Given this list of marker genes IL1RAP, CHRNA7, PIM1, PIEZO2, ENPP2, PBX3 (PBX homeobox 3), HOXA5, HOXA9, PDGFD, MMP2, SOCS2, GOLGA8A, QPRT, LGALS3BP, ADGRG1, SNRPN, HOXB2, IL2RA, LCT, BAHCC1, CYSLTR2, SMC4 (NCBI Gene Id 10593), MAP1A, COL4A5, TRPC2, NR6A1, HOXB6, SELENOP, HOXB3 (NCBI Gene Id 3213), TRGC1, ADCY2, APP, LYRM1, KCNK5, HOXB5, LAPTM4B, MRC1, TRIM16, HOXA4, MAGED1 (MAGE family member D1), PDE4B, here is a description of the gene set: from publication Valk PJ, Verhaak RG, Beijen MA, Erpelinck CA, Barjesteh van Waalwijk van Doorn-Khosrovani S, Boer JM, Beverloo HB, Moorhouse MJ, van der Spek PJ, Löwenberg B, Delwel R (PMID 15084694) Genes that best predicted acute myeloid leukemia (AML) with internal tandem duplications (IDT) in FLT3. Human Gene Set: VALK_AML_WITH_FLT3_ITD studied in species Homo sapiens BACKGROUND: In patients with acute myeloid leukemia (AML) a combination of methods must be used to classify the disease, make therapeutic decisions, and determine the prognosis. However, this combined approach provides correct therapeutic and prognostic information in only 50 percent of cases. METHODS: We determined the gene-expression profiles in samples of peripheral blood or bone marrow from 285 patients with AML using Affymetrix U133A GeneChips containing approximately 13,000 unique genes or expression-signature tags. Data analyses were carried out with Omniviz, significance analysis of microarrays, and prediction analysis of microarrays software. Statistical analyses were performed to determine the prognostic significance of cases of AML with specific molecular signatures. RESULTS: Unsupervised cluster analyses identified 16 groups of patients with AML on the basis of molecular signatures. We identified the genes that defined these clusters and determined the minimal numbers of genes needed to identify prognostically important clusters with a high degree of accuracy. The clustering was driven by the presence of chromosomal lesions (e.g., t(8;21), t(15;17), and inv(16)), particular genetic mutations (CEBPA), and abnormal oncogene expression (EVI1). We identified several novel clusters, some consisting of specimens with normal karyotypes. A unique cluster with a distinctive gene-expression signature included cases of AML with a poor treatment outcome. CONCLUSIONS: Gene-expression profiling allows a comprehensive classification of AML that includes previously identified genetically defined subgroups and a novel cluster with an adverse prognosis.